Given this list of marker genes SERBP1, PSMB2, RPA3, CKS1B, RIOX2, USP16, RCAN1, TUBB3, PRPS2, CKAP2, CPT1A, ZW10 (zw10 kinetochore protein), CD81, HSPE1, AIRIM, INSM1, DERA, NOL12, NEIL3 (nei like DNA glycosylase 3), LRIG1 (leucine rich repeats and immunoglobulin like domains 1), UTP18, GTF3A, EEF1B2, SRP9, PEX14, ARL6IP4, MTO1, CD200, PASK (NCBI Gene Id 26144), DDOST, R3HDM1, AKIP1, RRP7A, CSTPP1, GTF2A2, REXO2, SEH1L, XCR1, IMP3, RABGGTB, RGS10, POLG, NKAPD1, VGLL4, CTNNBL1, ROBO1, SUPV3L1, MLLT11, UBE3C, CD151, PUS7, AIMP2, LNPEP, CBFB, FANCE, EED, NMT1, ATXN3, TTC4, XPO1, GLS, DDX52, NDUFA8, AHI1, ILKAP, MRM2, PSMA2, JHY, NHP2, TMA16, DTWD1, DPAGT1, DPM3, AKAP1, C11orf58, HDHD5 (haloacid dehalogenase like hydrolase domain containing 5), MRPL4, IL10 (interleukin 10), STARD7, USP47, PSMD7, INTS7, FAM136A, LYRM2, ABRAXAS2, NENF, ILRUN, IRF4, ZNF395, ENTREP3, TGM5, SYNGR3, DAG1, GRSF1, QRSL1, DGCR8, STK25, SPSB1, TUBB6, C17orf75 (chromosome 17 open reading frame 75), RARS1 (arginyl-tRNA synthetase 1), MANF, TDP1, ANKRD55, GFI1, MGST3, METAP2, PINLYP, MAL, BFAR, FADD, CUL2, PAAF1, TRIM44, PHLDA1, EIF3F, BORA, TMEM208, TOMM22, ZZZ3, NUAK1, NOC3L, HDAC2, ESYT1, GNL2 (NCBI Gene Id 29889), MRPL49, NAT10, MRPL34, ATP2A2, PAFAH1B3, HEXA, SSB, RANGAP1, APOD, ZDHHC4, SLAMF1, ABCF2, NUCKS1, NEK2, COPS7B, HMGCS1, SDF2L1, KIFC1, GPN1, OSBPL3, ADRM1, ESD, ZNF32, ERCC2, BRCA1, NDUFA9, PSMA4, PTTG1, KNOP1, NIP7, RITA1, SRI, SUPT3H (SPT3 homolog, SAGA and STAGA complex component), MORC2, WEE1, HMGB3P1, SIRPG, NAA38, RUVBL1, SNRNP27, TRAF1, ZC3H14 (NCBI Gene Id 79882), TUBGCP2, MPG, LMNB2, RPS4X, HTATSF1, UBE2V2, HELLS, TMEM214, TOP3B, RUSC1, CEP15, ELOVL6, CA5BP1, MEAK7, PFAS, DIO1, MAP3K4, UNC119B, PMS2P5, ODC1, DDX18, NCL, MYC, CKS2, HAX1, FOXM1, NUDC, STARD5, EEF1E1, FKBP11, RCN1, RPL8, here is a description of the gene set: studied in species Homo sapiens from publication Jeffrey KL, Brummer T, Rolph MS, Liu SM, Callejas NA, Grumont RJ, Gillieron C, Mackay F, Grey S, Camps M, Rommel C, Gerondakis SD, Mackay CR (PMID 16474395) In the present study we used Affymetrix oligonucleotide microarrays to produce gene transcription profiles for the major leukocyte types in humans. This comprehensive dataset enabled us to not only establish which genes were expressed in each leukocyte type, but also which genes were expressed in each subset after activation. The used of a comprehensive dataset of gene profiles from all the major human leukocyte subsets enabled a novel and powerful means for identification of genes associated with single leukocyte subsets, or different immune paradigms. Genes down-regulated in comparison of neutrophils versus Th1 cells. Human Gene Set: GSE3982_NEUTROPHIL_VS_TH1_DN